Given this list of marker genes ESRRA, NPHS2, MINPP1, PNMA2, VWC2L, VWC2, TMEM100, ASAH2 (NCBI Gene Id 63292), LY86, PSMB10 (proteasome 20S subunit beta 10), SLC18A1, SFN, UTY, B4GALNT4, NOS2, EHD2, EPX, EXOC7, GOSR2, SAMD9L, CASP3, RNF31, NR1H2, HAT1, ZFYVE26, ZNF687, ITPR2, RPE, DRAM2, DGKA, NLRC5, SPHK2, HERC6, LY6E, RTCA, ST14, CYFIP2, TLR3, NEK11, TP53I11, DDHD1, RAG2, GAB2, KLRK1, NEK7, TENT2, NPC2, IL12B, GPR108, EPHA1, COL4A2, ENDOD1, BFAR, HLA-B, RBMS2, DPY19L1, TOR3A, CITED1, PHLDA2, CH25H, KCNN2, GYPC, IL12RB2, ALDH1B1, ADAMTS6, GULP1, LRRC41, HAPLN4, CACNG2, P2RX1, CXCR6, GCH1, CYP2W1, TAP2, ZNF260, FSTL5, MX2, CPNE3 (copine 3), OPTN, PLEKHH1, POLR2C, DBNL, PTCHD4, CST7, SLAMF8, TAL1, WARS1, WNK2, MEN1, NPNT, ACSL1, PML, LGALS7, HEATR5B, DLK2, DLK1, PLCL2, CD180, CCND1, TGM4, PCDHB7, FXR1, DYNC1I2, HLA-DRA, ZBTB2, SLC7A8, EVA1B, TAX1BP1, TNFRSF17, HUNK, ZNF768, PPM1L, KCTD7, NPAS1, NUDT13, PPP3CA (protein phosphatase 3 catalytic subunit alpha), RAB29, ATP6V1F, JUNB, WASHC4, RASA4, PSME1, RAB11FIP1, TICAM1, FNDC4, ELL3, SIGLEC1, PARP8, PFKFB3, DPF2, EVX2, DCAKD, VWA3B, RNASEL, AP2B1 (NCBI Gene Id 163), MDFIC, ZNF804A, ZBTB38, DCLK1, SLC28A2, ASTN1, CORO7 (coronin 7), MICU2, ZNF558, IL23A, OOEP, GCG, GJA1, MFSD1, SLAMF6, CRYL1, KIF9, ADAMTS12, TAP1, SHARPIN, IL7R, RAB8A, NFKBIA, EXT1, GPC1 (NCBI Gene Id 2817), MYBPC1, LMBRD1, CCDC150, PCGF1, TLK2, PPM1K, PBLD, SHC4, PPP1R11 (protein phosphatase 1 regulatory inhibitor subunit 11), SAP30, PHF6, STARD3, TWSG1, IL13RA2, TMEM108, AKAP12, IRF9, KCNJ10, PSME2 (proteasome activator subunit 2), FHIP1A, RALA, WNT2B, ENOX2, FAM171A1, RGCC, ASB6, SPATA18, MARCHF5, LIMS4, TRAFD1, LMOD2, TWIST1, NOVA2, MOCS2, UGGT2, GBP7 (guanylate binding protein 7), TFG, SSTR3, DRC1, here is a description of the gene set: Dendritic cells (DC) serve a key function in host defense, linking innate detection of microbes to the activation of pathogen-specific adaptive immune responses. Whether there is cell-intrinsic recognition of HIV-1 by host innate pattern-recognition receptors and subsequent coupling to antiviral T cell responses is not yet known. DC are largely resistant to infection with HIV-1, but facilitate infection of co-cultured T-helper cells through a process of trans-enhancement. We show here that, when DC resistance to infection is circumvented, HIV-1 induces DC maturation, an antiviral type I interferon response and activation of T cells. This innate response is dependent on the interaction of newly-synthesized HIV-1 capsid (CA) with cellular cyclophilin A (CypA) and the subsequent activation of the transcription factor IRF3. Because the peptidyl-prolyl isomerase CypA also interacts with CA to promote HIV-1 infectivity, our results suggest that CA conformation has evolved under opposing selective pressures for infectivity versus furtiveness. Thus, a cell intrinsic sensor for HIV-1 exists in DC and mediates an antiviral immune response, but it is not typically engaged due to absence of DC infection. The virulence of HIV-1 may be related to evasion of this response, whose manipulation may be necessary to generate an effective HIV-1 vaccine. species: Homo sapiens Genes down-regulated in monocyte-derived dendritic cells: control versus SIV infection. from publication Manel N, Hogstad B, Wang Y, Levy DE, Unutmaz D, Littman DR (PMID 20829794) Human Gene Set: GSE22589_HEALTHY_VS_SIV_INFECTED_DC_DN